Given this list of marker genes Aoc1l3, Aoc3, Maoa, Loxl4, Glud1, Rnls, Loxl3, Aoc1l1, Ddo, Loxl1, Lox, Aoc1l2, Loxl2, Dao, Lao1, Aoc1, Maob, Gldc, Aoc2, Aspdh, 4930438A08Rik, Pnpo, Vcam1, Il4i1, here is a description of the gene set: Catalysis of an oxidation-reduction (redox) reaction in which a CH-NH2 group acts as a hydrogen or electron donor and reduces a hydrogen or electron acceptor. Mouse Gene Set: GOMF_OXIDOREDUCTASE_ACTIVITY_ACTING_ON_THE_CH_NH2_GROUP_OF_DONORS species: Mus musculus